Given this list of marker genes IMPACT, PTGFR, ZCCHC3, MINDY2, NDC1, SLC30A5, C5orf58, PURA, FAM168B, UST, ZNF460, TSPYL5, SLC7A11, IPO9, NSL1, ZEB1, SETD5, MDM4, KIF1C, POU3F2, AOC3, PPARGC1A, FADS1, SAYSD1, SLC4A4, PAX5, ATP6V1H, C22orf46P, ACER2, IPO5, HNRNPH3, ADIPOR2, POM121, SLC16A12, FBXW11, GDI1, PPP1R3A, STOX1, ST6GAL1, ZNF490, SLC20A1, IBA57, LINC03105, CBL, HILPDA, HOXA2, COL19A1, KMT2A, CYP20A1, PRKAR1A, PSMB6, AICDA, ORAI2, PIK3AP1, TNF, SP1, MYB, SLITRK2 (SLIT and NTRK like family member 2), PAPPA, RAD23B, ANKRD12, TMSB4Y, ZNF346, SV2B, CMTM6, SPOPL, FBXL5, EIF5, VEZF1, ZC3HAV1, LRRC58, DENND4A, CD84, ITGAX, PRKCA, CLVS1, AIFM2, IKZF2, ZBTB4, PLP2, RORB, PKP4, MBTD1, SOWAHC, ADAM22, CDH7, ADAM19, NLRP7, POLH, IST1, LINC03104, CYP4X1, UBE2J1, RRM2 (NCBI Gene Id 6241), FSHB, MBD6, CLSPN, ZNF805, EPHB2, ELOVL3, KCNIP1, ZHX2, ZNF25, GABRG2, RC3H1, SNX30, TNRC6B (NCBI Gene Id 23112), OPA3, ZNF33A, TMED4, SETD7, IRGQ, TMEM108, NWD1 (NACHT and WD repeat domain containing 1), DCAF6, SNAP23, SZRD1, FKBP14, PPP2R2A, NPR3, CAMK2G (calcium/calmodulin dependent protein kinase II gamma), GK5, C1orf21, SEMA3A, ENSG00000277067, CHD2, VPS53, CDKN1B, TMPRSS11A, FTO, PIK3R1, VAPA, NR1D2, PERP, IL7, CHMP4C, ZFP91, SP5, SLC8A1, ACSL4, SNX7 (NCBI Gene Id 51375), TRMT12, NKX2-4, AHI1, CERS3 (ceramide synthase 3), SMC3, BSN, MOB1B, GPR26, SMIM14, MTCH2, TGDS, ENSA, BASP1, C6orf120, CTH, CPD, TADA1, ABCB9, XPNPEP3, WTAP, SESTD1, CD38, POM121C, RBM48, TDRP, ZFX, ZNF711, NRCAM, ZNF555, GGNBP2 (NCBI Gene Id 84160), PDE7A, PIRT, HSP90B1, here is a description of the gene set: Human Gene Set: MIR150_5P from publication Chen Y, Wang X (PMID 31504780) Genes predicted to be targets of miRBase v22 microRNA hsa-miR-150-5p in miRDB v6.0 with MirTarget v4 prediction scores > 80 (high confidence targets). studied in species Homo sapiens